Given this list of marker genes Cyp8b1, Ptgds, Akr1c21, Tbxas1, Ptges3, Ptges2 (NCBI Gene Id 96979), Hpgds, Ptgs2, Akr1c20, Ptges, Ptgis, Akr1c6, Ptgs1, Cbr1, here is a description of the gene set: species: Mus musculus Mouse Gene Set: REACTOME_SYNTHESIS_OF_PROSTAGLANDINS_PG_AND_THROMBOXANES_TX Synthesis of Prostaglandins (PG) and Thromboxanes (TX)